Given this list of marker genes NKX2-6, TBX1, PLD1, PLXND1, KNSTRN, PIK3CD, DDX6, here is a description of the gene set: Arteria lusoria Usually, three large arteries arise from the arch of the aorta: the brachiocephalic trunk (divided into the right common carotid artery and the right subclavian artery), the left common carotid artery, and the left subclavian artery. However, when aberrant right subclavian artery variant is present, the brachiocephalic trunk is absent and four large arteries arise from the arch of the aorta: the right common carotid artery, the left common carotid artery, the left subclavian artery, and the final one with the most distal left sided origin, the right subclavian artery, also called the arteria lusoria. Human Gene Set: HP_ARTERIA_LUSORIA species: Homo sapiens